The following is a description of a gene set: Genes up-regulated in CD11b+ cells from BALB/c mice bearing 4T1 mammary carcinoma: spleen of BALB/c mice: spleen versus tumor infiltrating monocytes. from publication Marigo I, Bosio E, Solito S, Mesa C, Fernandez A, Dolcetti L, Ugel S, Sonda N, Bicciato S, Falisi E, Calabrese F, Basso G, Zanovello P, Cozzi E, Mandruzzato S, Bronte V (PMID 20605485) Human Gene Set: GSE21927_SPLEEN_VS_4T1_TUMOR_MONOCYTE_BALBC_UP species: Homo sapiens Tumor growth is associated with a profound alteration of myelopoiesis, leading to recruitment of immunosuppressive cells known as myeloid-derived suppressor cells (MDSCs). Analyzing the cytokines affecting myelo-monocytic differentiation produced by various experimental tumors, we found that GM-CSF, G-CSF, and IL-6 allowed a rapid generation of MDSCs from precursors present in mouse and human bone marrow (BM). BM-MDSCs induced by GM-CSF+IL-6 possessed the highest tolerogenic activity, as revealed by the ability to impair the priming of IFN- -producing CD8+ T cells upon in vivo adoptive transfer. Moreover, adoptive transfer of syngeneic, GM-CSF+IL-6-conditioned MDSCs to diabetic mice transplanted with allogeneic pancreatic islets resulted in long term acceptance of the allograft and correction of the diabetic status. Cytokines inducing MDSCs acted on a common molecular pathway. Immunoregulatory activity of both tumor-induced and BM-derived MDSCs was entirely dependent on C/EBP transcription factor, a key component of the emergency myelopoiesis triggered by stress and inflammation. Adoptive transfer of tumor antigen-specific CD8+ T lymphocytes resulted in therapy of established tumors only in mice lacking C/EBP in myeloid compartment. These data unveil another link between inflammation and cancer and identify a novel molecular target to control tumor-induced immune suppression. We used gene expression analysis to identify those factors, secreted by tumor-infiltrating MDSC, which could drive emathopoiesis. Moreover we compare gene expression profile of tumor-induced MDSC, obtained from either the spleen and the tumor infiltrate of tumor bearing mice, and in vitro bone marrow-derived MDSC., and this is the list of marker genes: IFI30, BRSK1, TEAD3, CCHCR1, LINC00674, PGAM1, TRIT1, NUP62CL, SGSM2, UCMA (upper zone of growth plate and cartilage matrix associated), UBAP2, ADSL, INTS10, TRMT61A, SEC22A, C1QA, DNMT3A, FBLN2 (fibulin 2), PRR5, CLN8, CLCA2, RIMS3, GRIK1-AS1, CXCL2, ATP1B1, PCLAF, PDCD2L, INVS, PDZRN3, SMIM7, TUNAR, SPMIP10, CREG1, GBGT1, FAM230B (NCBI Gene Id 642633), CD38, PAG1, CXXC5, TEX47, NDUFS7 (NADH:ubiquinone oxidoreductase core subunit S7), H2BC12, CTBP2, MGAT4D, HDHD2, MORC2-AS1, LCNL1, SAMD13, TMEM9, ATP6V1C2, CORO1C, PCDH9, CMA1, BAD, TMEM170B, TMEM70, HRK, NATD1, MYRF (myelin regulatory factor), TAF4, RAG1, PTPRM, RPIA, B3GNT7, GAB3, PHACTR1, SP2-AS1, EHMT1, TMEM144, PWAR5, CKB, ZBED10P (NCBI Gene Id 113763), NPTX1, TAAR3P, CACHD1, TAPT1, CD47, SPP1, ATG4A, NUMB, DDX28, ACY1, ITGAM, BCKDHA, ANAPC2 (NCBI Gene Id 29882), SCIN, TMPRSS12 (transmembrane serine protease 12), ZNF503, SLC27A4, AMBP, RING1, LRRC37A5P, PKD2L2, GHRHR, FAM133B, CRYM, SORT1, BPNT1, TIMD4, UPK2, RNF130, FFAR4, GLCE, LEF1, NOLC1, DBN1, F11-AS1, GCNT1, CD79B, GRHPR, FABP1 (NCBI Gene Id 2168), SNX30, SPHKAP, TMEM176A, PIK3R1, RILPL2, RNASEH2C, METTL26, MRPS6, HIPK3, C3orf52, PRKAG3, COTL1, QTRT2, CREB3L2, CEP152, SCGB2A2, ORMDL3, ENPP6, CHML, CD300A, ELOA, CYTL1, GNAI2, CDH16, TMEM161A, KLRC3, LINC02483, CHST12, FOXD2, KIN, SNRNP25 (small nuclear ribonucleoprotein U11/U12 subunit 25), WDFY3, URB2, NUDT11 (NCBI Gene Id 55190), TMEM147, AOAH, VPREB3, RPS6KA3, CCDC127, PPP1CC, TMEM263, LINC01343, KCNG3, OLMALINC, LRRC14, OXLD1, FAM124B, NOD2, MAPK7, GLRX5, ATOX1, RRBP1, ZMIZ1, KIF21A, FZD10, SFTA3, CSRP1, TSEN54, CD86, S1PR5, ZNF718, NAA10, AP3S1, HMCES, PELI2 (pellino E3 ubiquitin protein ligase family member 2), ADGRL1, RCL1, TNFSF15, ACOX3, ACSM1 (NCBI Gene Id 116285), CAMK1D, ASB17 (NCBI Gene Id 127247), SLCO2B1, CHAD, FLACC1, SLC31A2, ETS2, NTN1, MAML3, ZNF232